Given this list of marker genes MTHFR, BHMT2, AHCYL2, MAT2B, AHCY, AHCYL1, MAT1A, MTRR, GNMT, METTL16, BHMT, MAT2A, here is a description of the gene set: studied in species Homo sapiens Human Gene Set: GOBP_S_ADENOSYLMETHIONINE_METABOLIC_PROCESS The chemical reactions and pathways involving S-adenosylmethionine, S-(5'-adenosyl)-L-methionine, an important intermediate in one-carbon metabolism.